The following is a description of a gene set: Posterior staphyloma A localized defect in the posterior eye wall with protrusion of uveal tissue due to alterations in scleral thickness and structure. Human Gene Set: HP_POSTERIOR_STAPHYLOMA studied in species Homo sapiens, and this is the list of marker genes: HADHA, IMPG2, ARL2, BEST1, PIGT (phosphatidylinositol glycan anchor biosynthesis class T), MC1R, OCA2 (OCA2 melanosomal transmembrane protein), CFAP410